Given this list of marker genes CDC25A, CCNE2, CDC25C, CCNA2, CDK2, SKP2, CDKN1A, CCND2, here is a description of the gene set: The phosphoinositide-3-kinase (PI3K)/AKT signaling pathway controls fundamental processes of cancer cell biology like proliferation and cell survival. The PI3K/AKT pathway is activated in pancreatic ductal adenocarcinoma (PDAC) cells. The molecular mechanisms linking PI3K signaling to the cell cycle machinery in PDAC cells are not investigated in detail. Using the PI3K inhibitor Ly294002 as well as small interfering RNA targeting AKT1 expression, we show that PI3K controls the proliferation and G(1) phase progression of PDAC cells. Gene profiling revealed several important regulators of G(1)-S phase progression controlled by PI3K signaling like p21(Cip1), S-phase kinase-associated protein 2 (SKP2), CDC25a, cyclin A, cyclin D2, CDK2, and cyclin E. We show that the F-box protein SKP2, an oncogene up-regulated in PDAC, is transcriptionally regulated by the PI3K/AKT1 pathway in PDAC cells. At the molecular level, the control of the SKP2 gene by PI3K is due to the regulation of E2F1 binding to the proximal SKP2 gene promoter. The complex and profound connection of PI3K/AKT1 signaling to the cell cycle qualifies this pathway as a suitable target for therapeutic intervention in PDAC. Human Gene Set: REICHERT_G1S_REGULATORS_AS_PI3K_TARGETS G1 to S phase regulators significantly changed in DanG cells (pancreatic cancer) treated with Ly294002, a phosphoinositide 3-kinase (PI3K) inhibitor. from publication Reichert M, Saur D, Hamacher R, Schmid RM, Schneider G (PMID 17483325) species: Homo sapiens